Given this list of marker genes SERPINC1, TOP6BL, F12, ABCC6, SYCP3, HTR1A, ANXA5, F2, F13B, ENPP1 (NCBI Gene Id 5167), F13A1, F5, here is a description of the gene set: Repeated episodes of abortion (Expulsion of the product of fertilization before completing the term of gestation) without deliberate interference. Human Gene Set: HP_RECURRENT_SPONTANEOUS_ABORTION species: Homo sapiens Recurrent spontaneous abortion